The following is a description of a gene set: Human Gene Set: REACTOME_TRANSCRIPTIONAL_REGULATION_BY_SMALL_RNAS species: Homo sapiens Transcriptional regulation by small RNAs, and this is the list of marker genes: H2BC13, POLR2B, POLR2G, H2AC14, H2AC20, POLR2E, H2BC14 (NCBI Gene Id 8342), POLR2J, H2BC26, SEC13, RAN, NUP188 (nucleoporin 188), H4C1, H4C9, H4C5, H2AC18, H3C13, H4C13, NUP54, NUP88, H2BC8, NUP58, AAAS, H2BC17, NUP155, NUP93 (NCBI Gene Id 9688), H2BC6, H2AZ2, H3-3A, H3C4, H2AC19, POLR2I, NUP35, H3C7, H2AC4, H2AC7, POLR2H, H3C11, TPR, POLR2K, H4C16, H4C6, NUP62, POLR2D, NUP98 (NCBI Gene Id 51457), H2BC9, H3C2 (H3 clustered histone 2), H3-3B, H4C15, POLR2A, IPO8, NUP214, NUP37, POLR2L, H4C3, H3C8, NUP205, H4C2, NUP85, H2BC12L (NCBI Gene Id 54145), POM121, H2BC1 (H2B clustered histone 1), POM121C, RAE1, H2BC3, H2BC15, H4C11, NUP210, H3C14, H2AJ, H3C12, RANBP2, H2BC4, H2BC7, NUP133, H3C3, H3C1, H2BC5, H2BC11, H2AX, NUP50, NUP153, SEH1L, POLR2F, TNRC6A (trinucleotide repeat containing adaptor 6A), POLR2C, H2AC8, H4C14, H4C12, NUP43, H3C6, H2BC21, AGO2, H4C8, NUP42, NUP160, AGO1, H3C10, H2AB1, H2BC10, NDC1, H3C15, H4C4, H2AC6, H2BC12, NUP107